The following is a description of a gene set: species: Homo sapiens Microarrays of gene expression in mouse germinal center B cells photoactivated in the light zone or dark zone, and of naïve cells for comparison. We used microarray data to identify genes differentially expressed by B cells in the light and dark zones of the germinal center. Human Gene Set: GSE23925_LIGHT_ZONE_VS_NAIVE_BCELL_UP Genes up-regulated in B cells: light zone versus naïve. from publication Victora GD, Schwickert TA, Fooksman DR, Kamphorst AO, Meyer-Hermann M, Dustin ML, Nussenzweig MC (PMID 21074050), and this is the list of marker genes: SLC35C1, GPR146, AMELX, METTL25B, ZBTB9, PPP1R15A, BCL2A1, RTL8B, STK17B, C1GALT1C1, IST1, BUD31, EVI2B, P2RX4, PTPRCAP, CCNL1, FCER1A, KBTBD2, FHL2, CASKIN2, UGT2B10, SLA (Src like adaptor), ATP11B, RILP, TGIF2, COQ10B, TRAF1, RHOG, MRPL52, VANGL1, SELPLG, FOSL2, NEAT1, C2orf88, SPNS2, GIMAP6, TMEM243, PHF6, BTBD19, IFNG, ETV3, PRDM4, RAB1A, PER2, HCCS, SH2D2A, JPH3, RNF125, PAQR9, KDM6B, GATA3, SRFBP1, DDX3X, ACTR5, CAMK2B, SAMSN1, NRROS, FRMD5, NAB2, NR4A1, CD69, BTG3, LENG9, CD6, ATF3, C14orf119, TSC22D2 (NCBI Gene Id 9819), GEM, FAM83D, CPNE5, FRMD4B, SIAH2, DPF3 (double PHD fingers 3), ETF1, BCL2, MNT, FILIP1L, HSD11B1, SDE2, C8G, SLC22A8, JUNB, DUSP1, ATG101, FASTKD5, TRIM13, TSPAN10, ZNF112, SBNO2, SGIP1, CDK5R1 (NCBI Gene Id 8851), SPMAP2L, SLC25A25, IER2, RANBP6, P2RY14, MLX, VAMP3, BAMBI, FBXL14, TWF1, MLLT11, EGR3, ZFP36, SRGN, CSRNP1, CBX8, OR7C1, MAFF, ITPKB, VPS37B, CCR4, PTPRN, PSMB4, TRIB1, SUB1, NR4A2 (nuclear receptor subfamily 4 group A member 2), PRDX6, SPRY1, CES1, MALT1, RILPL2, CYP4F22, PLK3, SLC6A8, PER1, NUDT11, ZFP36L1, SRPRA, MAGOH, STAC3, DUSP5, CYP8B1 (cytochrome P450 family 8 subfamily B member 1), GJC2, ZFP64 (ZFP64 zinc finger protein), TTLL3, PALLD, SRF, ISCU, ID3, MIR22HG, PNRC1, NFKBIZ, SFT2D1, CYTIP, MEX3C, GMPPB, KIF13B, NFKBID, NABP1, CACNA1A, IKZF2, POLR1D, TNFRSF1B (TNF receptor superfamily member 1B), TNFAIP3, SNX18, ATF4, YRDC, GPR171, DUSP6, CCL4, FBXO8, KCNQ5, BCL2L11, PABIR1, SIK1, PPP1R15B, CD5, TP53INP2, NR4A3, COL6A2, LRP12, PTPA, RINL, PRKAB1, DUSP2, TOB2, ELF5, TPM3, MSI1, TMEM63B, FOSB, MAP3K8, CBX4, DOK7, EGR2, ORAI1, ACTR1B, EGR1, ITPRIP, CD28 (NCBI Gene Id 940), ATP6V1E1, CHGB, UBALD1, NKIRAS1, TGIF1, FST, FOS (Fos proto-oncogene, AP-1 transcription factor subunit), ARL5B (NCBI Gene Id 221079)